Given this list of marker genes Selenbp2, Selenof, Gpx4, Gpx3 (glutathione peroxidase 3), Rph3a, Prdx2, Selenbp1, Dio1 (deiodinase, iodothyronine, type I), Selenop, here is a description of the gene set: Mouse Gene Set: GOMF_SELENIUM_BINDING species: Mus musculus Binding to a selenium (Se) ion.